The following is a description of a gene set: Expression profiling of Rag2-deficient Ets1++ and Rag2-deficient Ets1-- mature NK cells and WT bone marrow progenitors, WT T cells, and WT Pro B cells Human Gene Set: GSE37301_LYMPHOID_PRIMED_MPP_VS_PRO_BCELL_DN Genes down-regulated in lymphoid primed multipotent progenitors versus pro-B cells. species: Homo sapiens from publication Ramirez K, Chandler KJ, Spaulding C, Zandi S, Sigvardsson M, Graves BJ, Kee BL (PMID 22608498), and this is the list of marker genes: ST6GALNAC2 (ST6 N-acetylgalactosaminide alpha-2,6-sialyltransferase 2), CXCL13, WDR43, GUCY2F, ZNF804A, RAB11A (NCBI Gene Id 8766), ETNPPL, DCSTAMP (dendrocyte expressed seven transmembrane protein), SLC7A6, CCDC106, TP53TG5, CD55, CRB1, PTPRH, DNASE1L1 (deoxyribonuclease 1 like 1), BRIX1, LRFN3, PPP3CC, DSE, FETUB, CRYBB2P1, IMPG1, ISL1, CPLANE1, SI, GTF3A, IGFBP1, THRAP3, H2BC9, ITIH5, MGAT4C, CELF3, SH3BP4, GPRASP3, SEMA6B, DDX41, SLC29A2 (NCBI Gene Id 3177), SLPI, CLSPN, TNPO2, L1CAM, CSTF1, KIF1B, BRME1, EYA4, ZPR1P1, SLC9A1, SIGLEC15, MAP7D1, FRMD8, PCCB, NUBP1, IFI27, PLEK2, AHSG, EIF3J (eukaryotic translation initiation factor 3 subunit J), PSPH, TRBV10-2, PSG4, TLR8, ARHGAP11A, YJU2B, SLC22A4, FLI1, PIP, KIAA0408, ITIH3, MYOG, REEP5, CD68 (CD68 molecule), SECISBP2, PIGH, CNGB3, FKBP1A, LINC00652, RNFT2, IQCC, SERPING1, REG1A, GON4L (gon-4 like), EPYC, MICA (NCBI Gene Id 92319), DUX4L8, DHX34, KHDC1L, TMEFF1, PDCD6, ADISSP, TRPC5, DNM1, EHF, NNT, RNASEH2B, NYNRIN, TFAP4, NDUFAF4, GSTT4, AXL, ITFG1, RBP4 (retinol binding protein 4), NUDT6, SYT1, TCN2, UGGT1 (UDP-glucose glycoprotein glucosyltransferase 1), SNN, TEF, APOF, USP2, FOXA2, GRHL2, BNC1, ROPN1B, SCUBE2, EPHX2, ALOX15B, PADI1, MTMR10, C2 (complement C2), SPATA6L, RGS12, OR12D2 (NCBI Gene Id 26529), FCHO1 (FCH and mu domain containing endocytic adaptor 1), PABPN1, BTNL3, PIK3R4, TNFRSF10D, MAP3K13, ERC2-IT1, DCTN1, GPS1, KCNJ16, EIF2B1, CES1P1, SLC39A4, CBX2, FABP6, PSIP1, TRA2A, SPHK2, ZFP69B, POLR3D, CLEC1B, NSUN3, TNS3, ROBO1 (roundabout guidance receptor 1), ABCF2, GJB4, BTBD3, ORC5 (origin recognition complex subunit 5), ARMC1, TCP11, SORBS3, TMEM30B, FOSL1, ACYP2 (NCBI Gene Id 98), NPVF, MAGIX, STX10, FLT4, MCOLN1, ZSCAN9, CEMP1, PTDSS2 (NCBI Gene Id 81490), CCR10 (NCBI Gene Id 51565), BET1, DDX31, MDK, PAPOLB, CABIN1, PRM2, PRSS2, UTP14A, SORT1, PSEN2, SNRNP40, SEMA7A, IDH3G, MADCAM1, OSBPL7, TMEM144, EFS, GNGT1, CFAP43, PRSS8, CPNE6, WWC1, DNAAF8, CLDN14, NOP10, C1QBP, MRPS15, NDNF, TEKT2, EMSY, ERC2, TLE5